The following is a description of a gene set: studied in species Homo sapiens Human Gene Set: chrXp11, and this is the list of marker genes: LINC01284, MIR548AJ2, ENSG00000212347, FAM120C, CRIPTOP1, SMIM15P1, GAGE2E, SLC38A5, RPL23AP83, XAGE3, ZNF182, FOXR2, HSPB1P2, TATDN2P1, LINC03099, PYY3, CACNA1F, GAGE12B, PQBP1, MED14OS, CLDN7P1, MIR6895, MRPL32P2, MID1IP1, CENPVL3, GEMIN7P1, RNU6-722P, DDX3X, FDPSP5 (NCBI Gene Id 402397), ENSG00000228771, MPV17L2P1, RRAGB, PAGE2B, MTND2P24, NICN2P, ZXDA, SSX7, GAGE13, CHMP5P1, MIR532, OOEPP1, GAGE12H, PINCR, KANTR, TPMTP3, SSX11P, TIPINP1, SSX1, RN7SL291P, RNU6-504P, MIR660, NUS1P1, RPS15AP39, GPR34, XAGE2, TSPAN7 (NCBI Gene Id 7102), RBM10, H3P44, RNU6-202P, HMGB1P15, EZHIP, MTCO1P52 (MT-CO1 pseudogene 52), PGAM4P1, MRPS18CP7, PLLPP1, S100A11P5, NLRP2B (NLR family pyrin domain containing 2B), ITPK1P1, PLP2, CCDC120, PCNAP3, PPP1R3F (protein phosphatase 1 regulatory subunit 3F), BCOR, PAGE5, FGD1, RGN, KDM6A, NYX, RNA5SP503, MPC1L, MAGED4B (MAGE family member D4B), MIR222, PRAF2, APEX2, HSD17B10, PAGE1, CXXC1P1, MAGEH1, IPO7P1, SSX6P, RNU4-52P, CCNB3, LINC01283, VCF2, SDCBPP3, OTUD5, SYP-AS1, RNU12-2P, FAAH2, SPIN2B, RN7SL262P, LINC01560, GAGE12C, PPP1R11P2, SNORA11E (small nucleolar RNA, H/ACA box 11E), RNU6-29P, TIMM17B, SLC35A2, LINC01282, MAGED4, MIR501, PGAM1P7, YBX1P8, YWHAZP10, UBQLN2, SNORA11D, MIR4536-1, AKAP4, RPL7AP71, USP11 (ubiquitin specific peptidase 11), TFE3, PAGE4 (PAGE family member 4), UXT, GLOD5, SC4MOP, SPIN2A, SPACA5B, RPGR, SPIN3, GNL3L, ZNF81, RNU6-49P, ITIH6, KDM5C-IT1, MIR6857, VEZTP1, RNU6-421P, ZXDB, GPR82, SSX4B, RPS2P55, MIR221, RNU6-707P, VN1R110P, WDR45, SRSF6P1, RNA5SP504, RP2, VTRNA3-1P, MIR4536-2, RPSAP61, ENSG00000224610, SALL1P1, H2AL3, CASK, MAGED2, RNU6-1321P, NUDT11, SYP, USP27X-DT, IMPDH1P2, SHROOM4 (NCBI Gene Id 57477), RRM2P3, MIR362, MAGED1, CPSF1P2, LINC01496, IMPDH1P4, S100A11P10, SPANXN5, H2AP, JADE3, GAGE12J, PPP1R2C, ALAS2, SSX8P, WNK3, S100A11P8 (NCBI Gene Id 107985660), CASK-AS1, ZNF674 (zinc finger protein 674), GAGE2A, SRPX, LINC01281, ELK1, NDP-AS1, ZNF674-AS1, KCND1, DUSP21, SNORA11G, NDUFB11, RBM22P7, BAG1P1, RPSAP62, MIR3937, GAGE12F, SLC9A7, ENSG00000302958 (novel transcript), ENSG00000287215, SMC1A, SYN1, KDM5C, INE1, DGKK (NCBI Gene Id 139189), PSMA5P1, WDR13, GSPT2, MIR6894, RPL32P36, IQSEC2, SSX19P, FOXP3, TRO, ENSG00000308198, RNU6-630P, SHISA5P1, ZNF41, RPL7P57, ATP6AP2, CXorf38, ACAA2P1 (ACAA2 pseudogene 1), PFKFB1, PHF8, EFHC2, SSX15P, TBC1D25, RNU7-7P, PORCN, MAOA, MED28P4, ZNF157, DPRXP6, KRBOX4, LINC01545, GAPDHP65, FLICR (NCBI Gene Id 110437700), CTNNBL1P1, UQCR10P1, KRT8P17, RBM39P1, KLF8, LINC03053, CLCN5, MTHFD1P1, UBTFL11, CENPVL2, XAGE1A, RBM3, RPS11P7, XAGE1B, XAGE5, NDP, HDGFL3P1, HDAC6, WASF4P, GAGE1, MIR1587, MIR8088, ACTBP1, NBDY, GAGE12E, ZNF630-AS1, RIBC1, RNU6-1056P, NUDT10, CENPVL1, TSR2, RNU6-1124P, S100A11P6, FTLP16, OTC, GATA1, CLIC4P3, RNU6-591P, MRPL32P1, SSX21P, MAOB, EIF4A2P4, USP51, SYTL5, RNA5SP502, MED14, CHST7, MTND1P30, RNA5SP505, MIR98, FTSJ1, RNU6-935P, RPL37P24 (ribosomal protein L37 pseudogene 24), SMSP1, S100A11P9, MAGIX, ARAF, UQCRBP1, GAPDHP1, SPACA5, RNU6-50P, SNORA11, FAM156B, SSX18P, SSX4 (SSX family member 4), CFP, PRICKLE3, SUV39H1, FUNDC1, MIR188, ENSG00000295333, MDH1P1, NANOGP10, RN7SL144P, GOT2P6, RN7SL732P, USP9X, MIR4769, SSX3, RBM22P6 (NCBI Gene Id 644509), TNIP2P1, TIMP1, RNU7-164P, SSX13P, ACTG1P10, PCSK1N, GAGE12D, TSPYL2, CHTF8P1, GAGE12G, RN7SL785P, FAM156A, KRT8P14, HUWE1 (HECT, UBA and WWE domain containing E3 ubiquitin protein ligase 1), GPR173, SSX14P, SSX2B, KRT18P68, NPM1P49, PAGE3, BMP15 (bone morphogenetic protein 15), MIRLET7F2, MKI67P1, SSX2, EBP, GRIPAP1, PAGE2 (NCBI Gene Id 9505), ZNF630, ERAS, RN7SL15P, GAGE10, MID1IP1-AS1 (NCBI Gene Id 100874211), CDK16, SSX20P, MIR502, SSX5, DIPK2B, UXT-AS1, MIR222HG, LINC01204, UBA1, SSX9P, RNU6-434P, VDAC1P2, RPL19P20, USP27X, MIR500A, S100A11P7, LINC02601, LINC01186, PIM2, GPKOW (G-patch domain and KOW motifs), MIR500B, SPIN2P1, RNU6-1189P, WAS, MYCLP2, CCDC22, SNORA11C, ATP5MC2P4, PORCN-DT, DYNLT3